Given this list of marker genes Jak1, Gh, Tyk2, Jak2, Jak3, Socs2, here is a description of the gene set: Mouse Gene Set: GOMF_GROWTH_HORMONE_RECEPTOR_BINDING Binding to a growth hormone receptor. species: Mus musculus